Given this list of marker genes Hexa, Hexb, Gla, Naga, Neu2, Lct, Gm2a, Pnliprp2, Prkcd, Gba1, Neu1, Galc, Neu4, Gba2, Neu3 (neuraminidase 3), Glb1, Psap, here is a description of the gene set: Mouse Gene Set: GOBP_GLYCOLIPID_CATABOLIC_PROCESS The chemical reactions and pathways resulting in the breakdown of glycolipid, a class of 1,2-di-O-acylglycerols joined at oxygen 3 by a glycosidic linkage to a carbohydrate part (usually a mono-, di- or tri-saccharide). studied in species Mus musculus